The following is a description of a gene set: Fibronectin (FN1) is found in the extracellular matrix (ECM) of all cells as linear and branched networks that surround and connect neighbouring cells. Prior to matrix formation FN1 exists as a protein dimer. Often the two peptide chains represent differentially-spliced variants. The chains are linked by a pair of C-terminal disulfide bonds which are essential for subsequent multimerization. FN1 monomers have a molecular weight of 230-270 kDa depending on alternative splicing and contain three types of repeating unit, I, II, and III. I and II are stabilized by intra-chain disulfide bonds. The absence of disulfide bonds in type III modules allows them to partially unfold under applied force. Three regions of variable splicing occur along the length of the FN1 monomer (Mao & Schwarzbauer 2005). One or both of the 'extra' type III modules EIIIA and EIIIB may be present in cellular FN1, but never in plasma FN1. A variable (V) region exists between the 14th and 15th type III module. This contains the binding site for alpha4 beta1 and alpha4beta7 integrins. It is present in most cellular FN1, occasionally in plasma FN1. The modules are arranged into several functional and protein-binding domains. There are four FN1-binding domains (Mao & Schwarzbauer 2005). One of these domains (I1-5), referred to as the 'assembly domain', is required for the initiation of FN1 matrix assembly. Modules III9-10 correspond to the 'cell-binding domain' of FN1. The Arg-Gly-Asp (RGD) integrin binding sequence located in III10 is the primary site of FN1 to cell attachment, mediated predominantly by alpha5 beta1 and alphaV beta3 integrins. The 'synergy site' in III9 modulates FN1's association with alpha5 beta1 integrins. FN1 also contains interaction domains for fibrin (I1-5, I10-12), collagen (I6-9, II1-2), fibulin-1 (III13-14), heparin, syndecan (III12-14) and fibrillin-1 (I6-9) (Mao & Schwartzbauer 2005, Sabatier et al. 2009).<br><br> FN1 dimer binding to alpha5beta1 integrin stimulates self-association. Binding is thought to lead to a conformational change in FN1 that triggers the addition of further FN1 dimers. I1-5 functions as a unit that is the primary FN1 matrix assembly domain but other units are likely to be involved, the process is not fully understood.<br><br>Several ECM proteins appear to require the FN1 matrix for their own assembly. Fibrillin-1 containing microfibrils are formed when fibrillin-1 multimers bind to the FN1 matrix. FN1 polymerization promotes the deposition of type I and type III collagen. Inhibition of FN1 polymerization increases its turnover and a concomitant loss of collagen types I and III from the ECM. FN1 is regulated by matrix metalloproteinases, particularly MMP14 (Shi & Sottile 2011). part of: Extracellular matrix organization studied in species Homo sapiens Reactome Pathway: Fibronectin matrix formation, and this is the list of marker genes: COL1A2, COL2A1, CEACAM8, COL4A1, CEACAM1, COL5A1, COL5A2, COL5A3, COL7A1, COL4A6, ITGB1 (integrin subunit beta 1), COL4A2 (NCBI Gene Id 1284), COL4A3, FN1, COL4A4, ITGA5, COL3A1, CEACAM6, COL4A5, COL1A1